Given this list of marker genes HAVCR2, SRP54-AS1, PRRT2 (NCBI Gene Id 81865), PEAK3, PEX11G, ARRDC3, IGKV1-6, CD1A, DACT1, here is a description of the gene set: Genes down-regulated in B cell 7d vs 0d in adults after exposure to 2011-2012 trivalent inactivated vaccine (A/California/7/09 (H1N1), A/Perth /16/2009 (H3N2), B/Brisbane/60/2008), time point 7D. Comment: Down-regulated DE RNA transcripts (down >= 1.5x) shared between both TIV-vaccinated donors species: Homo sapiens from publication Hoek KL, Samir P, Howard LM, Niu X, Prasad N, Galassie A, Liu Q, Allos TM, Floyd KA, Guo Y, Shyr Y, Levy SE, Joyce S, Edwards KM, Link AJ (PMID 25706537) Human Gene Set: HOEK_B_CELL_2011_2012_TIV_ADULT_7DY_DN Systems biology is an approach to comprehensively study complex interactions within a biological system. Most published systems vaccinology studies have utilized whole blood or peripheral blood mononuclear cells (PBMC) to monitor the immune response after vaccination. Because human blood is comprised of multiple hematopoietic cell types, the potential for masking responses of under-represented cell populations is increased when analyzing whole blood or PBMC. To investigate the contribution of individual cell types to the immune response after vaccination, we established a rapid and efficient method to purify human T and B cells, natural killer (NK) cells, myeloid dendritic cells (mDC), monocytes, and neutrophils from fresh venous blood. Purified cells were fractionated and processed in a single day. RNA-Seq and quantitative shotgun proteomics were performed to determine expression profiles for each cell type prior to and after inactivated seasonal influenza vaccination. Our results show that transcriptomic and proteomic profiles generated from purified immune cells differ significantly from PBMC. Differential expression analysis for each immune cell type also shows unique transcriptomic and proteomic expression profiles as well as changing biological networks at early time points after vaccination. This cell type-specific information provides a more comprehensive approach to monitor vaccine responses.